The following is a description of a gene set: studied in species Homo sapiens Human Gene Set: HP_ABNORMALITY_OF_ENDOCRINE_PANCREAS_PHYSIOLOGY Abnormality of endocrine pancreas physiology A function abnormality of the endocrine pancreas., and this is the list of marker genes: DIS3L2, SLC16A1, KCNJ11, FAH, VHL, UCP2, STAT3, MAFA, GCGR, PAX4, GPC3, LBR, CDKN1B, EIF2AK3, INS, GCK, HAMP, INSR, CDKN2C, HJV, CDKN2B, ABCC8, PDX1, CDKN1A, MEN1, CCND1, GPC4, YY1, HNF1B, GLUD1, HNF4A